The following is a description of a gene set: Human Gene Set: GSE23925_DARK_ZONE_VS_NAIVE_BCELL_DN studied in species Homo sapiens Microarrays of gene expression in mouse germinal center B cells photoactivated in the light zone or dark zone, and of naïve cells for comparison. We used microarray data to identify genes differentially expressed by B cells in the light and dark zones of the germinal center. from publication Victora GD, Schwickert TA, Fooksman DR, Kamphorst AO, Meyer-Hermann M, Dustin ML, Nussenzweig MC (PMID 21074050) Genes down-regulated in B cells: dark zone versus naïve., and this is the list of marker genes: MAP3K11, HTR1A, MAPK8IP1, SRF, PNRC1, C14orf119, ARID5A, STK17B, VPS37B, MAG, ITPRIP, EGR1, POTEH, CDA, RAPSN, ST18, SPATA2, SRGN, IFFO2, CCND3, ADORA3, EGLN2, TMA7, BTG3, SUB1, SRFBP1, SLC3A2, PLA2G12B, SLC36A3, RILPL2, MYOD1, MED31, FOSB, ISCU, ZFP36, SCAND1, LRRC73, CCHCR1, RINL, NACC1, NUMBL, AUH, YRDC, COL11A2, OAF, XCL1, EFEMP1, DUSP2, AQP12A, MAPK8IP2, PWWP2B (NCBI Gene Id 170394), CES4A, JUNB, BCL2L11, NCKAP5L, PPME1, TMEM131L, PLK3 (NCBI Gene Id 1263), CD69, TOB2, BCL10, LYPD6, PTPN21 (protein tyrosine phosphatase non-receptor type 21), OTULIN, TNF, MEX3D, GPR171, DUSP1, CABP5, MLLT11, EIF1B, IFNG, ZRSR2, LTV1, KBTBD2, MAFF (MAF bZIP transcription factor F), NRXN2, LTK, NCOA7, NR4A2, PTPN23, MAP3K9, CCDC86, HSPA5, PRDX6, GATA3, ZMYND8, HPCAL4 (NCBI Gene Id 51440), MOB3A, CCNL1, TNFRSF21, PQBP1, EGR3, ZFP64 (ZFP64 zinc finger protein), CDK5R1, ATG101, LONP1, KDM2A, NCAN, NMU, PER1, ENPP2 (ectonucleotide pyrophosphatase/phosphodiesterase 2), JAM3, ID3, SPRY1, KTI12, PRSS46P, C2orf88, AOX1, ACTR1B, NFKBIZ, EGR2, TMEM243, MAPK6, KLHL18, CSRNP1, NOL12, SRPRA, EYA3, SH2D6, TP53INP2, MAGI1, LY6G6D (NCBI Gene Id 58530), NR4A1, PIM3, IER2, SELPLG, GCH1, NPTX2, ASCL3, CASKIN2, SLA, TNFAIP3, MOCS3, FOS, GCC1, PTPN1, ZBTB48, SPINK5, VAMP2, TRMT10C, HCN3, PPT2, TGIF2, LENG9, NFKBID, MIDEAS, ITPKC, HCLS1, SH2D2A, PLVAP, TEX11, DMTN, PPP1R15B, LMO4, AAR2, DNAJB1, PHF6, SNX18, CSRP1, ETF1 (eukaryotic translation termination factor 1), SENP3, ZFP36L1, SLC5A6, DNAH12, ARL5B (NCBI Gene Id 221079), FBXO33, CACNG5, ADRA1B, TRIB1, TMEM150A, GEM, CTRC, NLRP9, MFNG, ORAI1, SLC39A3, CCL4, OCEL1, ZCCHC14, NPY5R (NCBI Gene Id 4889), ATP6V0C, PTTG1, F12, NR1H2, PRKAB1, ETV3, DUSP6, PIK3CD, CDC42SE1, GPRC5C, SEMA4D, DUSP5, FXR2, BCDIN3D, CBX4, ZBTB9, UNC13D, TRAF4, BCL2A1